The following is a description of a gene set: species: Mus musculus The region that lies just beneath the plasma membrane on the apical edge of a cell. Mouse Gene Set: GOCC_APICAL_CORTEX, and this is the list of marker genes: Prkcz, Tchp, Sapcd2, Hamp2, Sptbn5, Insc, Myo5b, Hamp, Fabp2, Nlrp5, Fabp1